Given this list of marker genes EFNA2, APP, ARF4, COMT, ALDH18A1, RHPN2, NSFL1C, ACOD1, SVIL, CD300C, ZNF652, ETV3, IDH2, SLC30A6 (NCBI Gene Id 55676), S100A6, PLCD1, SMIM13, RIOK1, PRDM15, GDAP2, SLC22A23, CORO2B, YAE1, CHD2, ITGAX, TM9SF2, TSPO, DNAJC13, ADAM8, BMPR2, SIGLEC7, NDUFB4, SOAT2, AP4B1, AKIRIN1, PNPO, YPEL2, DICER1, ECSCR, EEF2K, STX3, LTF (lactotransferrin), DNAJC1, NDUFB6, FPR2, SPHK1, DNAJA3, IER3, ITIH5, NUDT17, FOSB, PDZD4, TRIM24 (NCBI Gene Id 8805), PON1, CALCOCO1, DDX56, RIOK3, AUP1, RTN3, SCAMP2, ARHGAP6, ZNF35, ATG9A, FAM3A, TOR2A, RPL41, APPL1, CTSE, LAX1, UQCRQ, SGCB, SRPRA, C15orf40, POGLUT2, DPY19L1, ATXN1, PRICKLE3, ANKRD6, RAB39B (NCBI Gene Id 7489), SLC11A2, TAX1BP1, LZTFL1, CREG1, MMACHC, MAB21L3, EME2, DYM, GPR108, KCNN4, KIAA1217, JOSD2, PIGB, CCDC146, ELP5, CEP76, SLC11A1, NEK6, CXCL10, ATF6B, PPA1, CACNA1H, FEM1A, RAB11FIP1, CHCHD7 (coiled-coil-helix-coiled-coil-helix domain containing 7), SLC25A23, MRPL20 (NCBI Gene Id 64994), SLC3A2, PPM1H, NBEA, UXS1, DCTN6, CLU, FCGR2A, PNRC1, SMOX, SNAP47, NSG1, KHK, MOCS2, ADCY6, FKBP2, SPR, UPF3A, HARBI1, CACNB3, TGFBI, H1-0, POLR3D (NCBI Gene Id 661, RNA polymerase III subunit D), OXNAD1, HS2ST1, TESC, IMPA2, SCFD2, TOR1B, NSMCE2, HCAR2, F10, LIMK1, SLC27A1, RAB3D, UFC1, OSBP, GOLGA5, EDF1, FBXO17, ACTR10, MDH2, SEC11C, ANXA6, AGRN, LSR, GLCE, GBA2 (NCBI Gene Id 57704), RECK, TOM1L2, RCHY1, KDM5B, PREB, GGPS1, MIA3, POLR2I, LAMB2, EAF2, GPATCH2, NDUFV3, CD177, SERINC3, IL1B, CLN8, CYB561D2, STX8, PELO, GFI1, SLC33A1, PCCB, TMEM230, TMEM263, RREB1, EBAG9, CRADD, EFCAB3 (EF-hand calcium binding domain 3), AHNAK2, GOSR2, PTPN9, PHYH, SLC50A1, MRPL54, TF, MCEE, SRP68, MKNK1, SLFN12, LOXL2, GCDH, DCAF6, ARSB, SH3BP5L, TRABD (TraB domain containing), GNE, DSEL, here is a description of the gene set: studied in species Homo sapiens from publication Lund R, Aittokallio T, Nevalainen O, Lahesmaa R (PMID 14607935) Human Gene Set: GSE2770_UNTREATED_VS_IL4_TREATED_ACT_CD4_TCELL_48H_UP Th1 and Th2 cells arise from a common precursor cell in response to triggering through the TCR and cytokine receptors for IL-12 or IL-4. This leads to activation of complex signaling pathways, which are not known in detail. Disturbances in the balance between type 1 and type 2 responses can lead to certain immune-mediated diseases. Thus, it is important to understand how Th1 and Th2 cells are generated. To clarify the mechanisms as to how IL-12 and IL-4 induce Th1 and Th2 differentiation and how TGF-beta can inhibit this process, we have used oligonucleotide arrays to examine the early polarization of Th1 and Th2 cells in the presence and absence of TGF-beta after 0, 2, 6 and 48 hours of polarization. Genes up-regulated in CD4 T cells: untreated (0h) versus activated by anti-CD3 and anti-CD28 and then stimulated by IL4 (48h).